The following is a description of a gene set: species: Homo sapiens from publication Chen Y, Wang X (PMID 31504780) Genes predicted to be targets of miRBase v22 microRNA hsa-miR-924 in miRDB v6.0 with MirTarget v4 prediction scores > 80 (high confidence targets). Human Gene Set: MIR924, and this is the list of marker genes: CDKL3, WEE1, AXL, DCBLD2, COMT, ELK1, EYA2, PAG1, TAF5L, DUSP5, TFG, ZBTB33, USP42, NUP160, SGCD, TBC1D8B, FAM78A, SDHD (succinate dehydrogenase complex subunit D), MACO1, IL36G, BEND2, NYAP1, TMEM67, YBX2, MAP3K1, HIRIP3, PIK3AP1, PCSK1, MR1, RALGAPB, FAM20A, FCHSD2, ARPC5L, AGMAT, SULF1, SKIL, MMACHC, WTAP, WIPF2, ELOC, KIRREL2, BMPER, VWA3A, SELENOP, TENM4, RGMB, TWF1, TIMD4, AFAP1L2, SPRY2, MAN2B1